Given this list of marker genes S100A8, COL13A1, TNNC1, KIT, SPARCL1, SORBS1, MAP4, RDH11, CDK14, TANGO2, EPB41, PRKCE, ACTA1, ENG, IGFBP6, ACSL1, HCK, TOP2A, LIFR, ANKRD1, LAMA2, OMD, METAP1, TBX2 (NCBI Gene Id 6909), FERMT2, GPAM, ACKR3, TNXB, KANK3, BPGM, TCF21, MGP, USP18, PDLIM1, ART3, ZEB1, NID1, ADGRE5, MS4A1, SPOCK2, DUSP1, PLTP, SEMA3C, AQP1, SPTAN1, GGH, CAVIN1, S100A9, EPS15, AHR, NUMB, TNFRSF19, PKIA, CCN5, VWF (NCBI Gene Id 7450), CYP2A6, CDO1, AHNAK, ITPKB, MYL4, XIST, ALDH1A1, NDN, DNM1, COL3A1, MPDZ, HOPX, ANKRD40, MYH11, MEF2C, THBD, TEKT1, GUCY1B1, PEG3, MYL3, GSTM1, CLIC4, LIN9, IFIT3, CXCL14, PMP22, DPT, ABCC1, GSN, GPC3, ATP1A2, EMP2, SULT1A1, SULT1D1P, EPAS1, CCKAR, ADH1A, EDNRB, SEPTIN4, PON1, BCL6B, ADCY8, LYVE1, TNNT3, RGS2, ADRB3 (NCBI Gene Id 94406), MYL9, MYH6, RIPOR2, MEIS1, CALCRL, CDR2, LOX, CLEC3B, ATP2A2 (NCBI Gene Id 488), CYP2E1, GPX3, CYP2F1, SHOX2, FYN, G0S2, PPP2R3C, ZBTB46 (zinc finger and BTB domain containing 46), SERPINA3, SRGN, SIAH1, PTPRD, TSPAN6, CA3, NDRG2, CDH11, SCEL, ANKRD33B, CCRL2, PGRMC1, H2BC4, KCTD12, CP, NDST1, NR2F2, PTGES, GRK5, KLF7, CLDN5 (claudin 5), CD47, CCL21, ROBO1, PLPP1, SLC7A5, HBB, FXYD1, PCDHA9, CIDEC, ABLIM1, USF2, ACTA2, VEGFD, IFIH1, FHL1, CFHR1, IL6ST, HOXB5, MFAP2, FLT1, MFAP5, FKBP9, PCK1, TAGLN, CKMT2, SH3BP5, ABCA1, INMT, GPM6B, CYP4B1, TNS2, TPH1, EPHA5, DCN, COL1A1, LAMB1, ARMCX2, RBP1, MYZAP, LOXL1 (NCBI Gene Id 4016), GBP2, CAV1, VAMP3, SMAD6, ADARB1, ACE, SLC4A5, POSTN, SCN7A, MYO6, CYP2S1 (cytochrome P450 family 2 subfamily S member 1), NFKBIA, MTSS2, KDR, TSPAN7 (tetraspanin 7), RASIP1, GIMAP4, WWTR1, KALRN, BMP6, CFD, TRBC1, REG3G, HOXA6, MYB, IGFBP5, MSLN, CES1, TIAM1, SPTBN1, ARHGEF3, PRX, NT5DC2, RARRES2, RAB12, FAS, TWSG1, ACKR4, PSIP1, ALAS2, KLF4, KLF9, CAV3, ANKRD10, IFI16, LATS2, SOX11, SATB1, GNG2, CYP2B6, FMO3, CES2, PSMB10, ETS2, SNCA, ACVR2A, TM2D3, VCL, MACF1, PAPSS2, FGF7, LTB, IL11RA, TUBA1A, ADIPOQ, MYO1B, BUB1, ANGPT1, CD93, LYL1, SC5D, SERPING1 (serpin family G member 1), FOXF1, KLF2, SASH1, VAX1, CNTN1, H2AX, LORICRIN (loricrin cornified envelope precursor protein), KRT4, GNAS-AS1, CYTH3, LMO2, TCF3, HP, TMEM71, PRDX6, ADRB2, ZBTB20, LYSMD2, DENND4C, TNNT2, GFRA2, MS4A6A, LEPR, SCGB1A1, GADD45B, ACVRL1, SOD3, SLC10A2, QKI, ARRB1, RAMP2, KRT13, TFRC, CRIP1, MARCKS, EMCN, FGL2, DPEP1, GPR182, TENT5C, ATOH7, HOXA5, BDNF (brain derived neurotrophic factor), ANGPTL2, GMFG, BNC1, TNNI3, TEK, NFIB, SOX2, PAM, CFH, ID3, PDGFRB, JUN, TPRG1L, LIMCH1, SPARC, LTBP4, ENPP2, COL1A2 (collagen type I alpha 2 chain), IGFBP2, COX7A1, TJP1, PTCH1, MEOX2, TFPI, STAB1, GBP4, OGN, EFNB2, KITLG, CALCR, PAG1, MYL7, PPP1CB, EDN1, TCF4, ALDOB, VEGFA, INPP5A, RHOB, MYH1, IFITM3, SEMA7A, TIMP3, TIE1 (tyrosine kinase with immunoglobulin like and EGF like domains 1), CADM1, ZMYND11, PKD2, HEPH, STMN3, PLAC9, TSPAN13, PGM2, HSD11B1, FGF9 (NCBI Gene Id 2254), GLUL (NCBI Gene Id 2752, glutamate-ammonia ligase), UPK3B, RHOJ, PLPP3, C3, HNRNPA1L2, CDH5, ETS1, ANTXR2, SESN1, TBX3, CXCR4 (C-X-C motif chemokine receptor 4), SOX17, FOXF2, TMEM45A, TMEFF1, ACTC1, SLCO3A1, DENND2B, SPIB, ACKR2, ENAH, CCN1, IL1B, ICAM2 (intercellular adhesion molecule 2), CACNB2, CAVIN2, RCN1, IL27RA, CPE, RABGGTA, SPA17, PDGFRA, GYG1, NOTCH4, NPR3, GNB4, SPEF1, HEY1, MFHAS1, FMO1, CRHR1, ZBTB16, MAP7D1, PTPRB, STMN2, BPIFB1, RAB28, SHE (NCBI Gene Id 126669), COL6A2, GREM2, SMARCA2, CA2, IGHD, ST8SIA4, NPNT, SURF2, PROM1, DIPK2A, CAVIN3, PTGIS, SSPN (sarcospan), NTN1, AKAP12, RECK, RPTN, FEZ2, CDKN1C, KRT85, MAPT, GNG11, here is a description of the gene set: species: Mus musculus from publication Sweet-Cordero A, Mukherjee S, Subramanian A, You H, Roix JJ, Ladd-Acosta C, Mesirov J, Golub TR, Jacks T (PMID 15608639) Genes down-regulated in the Kras2LA mouse lung cancer model with mutated KRAS. Using advanced gene targeting methods, generating mouse models of cancer that accurately reproduce the genetic alterations present in human tumors is now relatively straightforward. The challenge is to determine to what extent such models faithfully mimic human disease with respect to the underlying molecular mechanisms that accompany tumor progression. Here we describe a method for comparing mouse models of cancer with human tumors using gene-expression profiling. We applied this method to the analysis of a model of Kras2-mediated lung cancer and found a good relationship to human lung adenocarcinoma, thereby validating the model. Furthermore, we found that whereas a gene-expression signature of KRAS2 activation was not identifiable when analyzing human tumors with known KRAS2 mutation status alone, integrating mouse and human data uncovered a gene-expression signature of KRAS2 mutation in human lung cancer. We confirmed the importance of this signature by gene-expression analysis of short hairpin RNA-mediated inhibition of oncogenic Kras2. These experiments identified both a pattern of gene expression indicative of KRAS2 mutation and potential effectors of oncogenic KRAS2 activity in human cancer. This approach provides a strategy for using genomic analysis of animal models to probe human disease. Human Gene Set: SWEET_LUNG_CANCER_KRAS_DN